The following is a description of a gene set: studied in species Mus musculus Mouse Gene Set: GOBP_NEGATIVE_REGULATION_OF_PROTEASOMAL_UBIQUITIN_DEPENDENT_PROTEIN_CATABOLIC_PROCESS Any process that stops, prevents, or reduces the frequency, rate or extent of the breakdown of a protein or peptide by hydrolysis of its peptide bonds, initiated by the covalent attachment of ubiquitin, and mediated by the proteasome., and this is the list of marker genes: Trim39, Nop53, Rybp-ps, Taf9, Caml, Hsp90ab1, Smarcc1, Styx, Shh, Gipc1, Usp38, Styx-ps, Pbk, Klhl40, Usp26, Csnk2b, Usp9x, Usp7, Senp1, N4bp1, Bag6, Eif3h (eukaryotic translation initiation factor 3, subunit H), Ogt, Wac, Tlk2, Hfe, Csnk2a2, Fhit, Ccar2, Mtm1, Ttc36, Pabpn1l, Clec16a, Rybp, Uchl5, Bag5, Park7, Map1a, Ubxn1, Rpl11, Ddrgk1, Phf20l1